The following is a description of a gene set: Reactome Pathway: MET activates RAP1 and RAC1 studied in species Homo sapiens The adapter protein GAB1 is involved in recruitment, through CRK and related CRKL proteins, of guanyl nucleotide exchange factors (GEFs) to the activated MET receptor. MET-associated GEFs, such as RAPGEF1 (C3G) and DOCK7, activate RAP1 and RAC1, respectively, leading to morphological changes that contribute to cell motility. part of: MET promotes cell motility, and this is the list of marker genes: CRKL, RAC1 (NCBI Gene Id 5879), GRB2, DOCK7, RAP1B, RAP1A, MET, HGF, GAB1, RAPGEF1, CRK